Given this list of marker genes DPAGT1, PDCD7, SLC37A4, HTATSF1, CARHSP1, TMEM14A, NARS2, PPP1R7, PNKP, MAT2A, RNASE4, MARK3, EIF3L, SLC7A3, PANK2, PUS3, DUSP6, PRDX3, MOB1B, MRPL46, LAP3, WDR38, TNIP2, MAN2A1, PIK3R1, PPP4R3B, NDFIP2, GMDS, CRIP1, ACTR10, AHCYL1, CTDNEP1, MACIR, RAP1A, CXCR5, PI4K2B, ENO1, CPOX, NRBF2, CNOT6L, MTM1, SMARCA5, DUSP2, TM6SF1, BMAL1, RAMP1, RBM28, TMEM242, GOLPH3L, SSRP1, SLC35F5, TXN2, TAF12, MRPS35, DHX9, DDX46, CSNK2A1, MPHOSPH10, TNIK, EXOSC5 (exosome component 5), ALDH18A1, UBE3D, HLA-DOA, TDP1, PITPNA, MND1, ALG1, TMEM237, PARG, POLR3C, AIM2 (NCBI Gene Id 9447), ATP8B4, MDH1, MMS22L, OGDH, CNPY4, TMEM18, KMT2E, ALDOC, ZFYVE21, PPM1E, TMEM192, CD79A, MTHFD1, MRPS12 (mitochondrial ribosomal protein S12), AFG3L2, CWH43, SAT1, CDC5L, PAICS, BECN1, ATL2, TIA1, FAF2, SHMT1, DDX50, STAT1, GNB4, LINC00511 (long intergenic non-protein coding RNA 511), G6PD, CCDC51, FAM50A, CUL2, EIF2A, ZBTB12, RRAD, ARL4A, GNPNAT1, LYRM1, METTL27, CD69, TRAPPC3, USP31, ROM1, OTUD5, GBP7, SPIDR, MED11, PTGR2, WDR83, FBXO32 (NCBI Gene Id 114907), ZFAND5, SLC7A5, TMEM70, PIAS4, ANAPC16, TNFRSF18, GCSH, ECI1, POP4, ERAP1, EIF3D, ALG14, ERCC5 (NCBI Gene Id 2073), CASP8, TRMT6, HSD17B7, DDX5, DDX19B, RPS6KA3, ASTE1, B3GNT5, PIH1D2, MCOLN2, FAM133B, CSRP1, MTHFD1L, ZSWIM7, CSNK1A1, CYB5B, CRNKL1, NDUFAF7, EIF3J, BCAR3, BBS7, MAN1A1, PARP4, OSTM1, CPSF3, PON2, MTCP1, STK38, RPS21, UCHL1, KYAT3, NUDCD2, BORCS6, ZNF292, RBM22, ESD, TMEM11, TCEAL1, MTARC2, MTA2, PRXL2C, JOSD2 (Josephin domain containing 2), INIP, LDAF1, CEP135, NCK1, ABCB6, MTERF1, SATL1, CHAF1B, ATG5, NDST2, ZNF277, EFL1, NFS1, CRISP3, DHX15, GFM1, BRMS1 (NCBI Gene Id 25855), TIMM8B, P2RY10, FAM111A, PSAP, CBX8, CENPO, PAK1IP1, here is a description of the gene set: Human Gene Set: GSE20198_IL12_VS_IL12_IL18_TREATED_ACT_CD4_TCELL_UP studied in species Homo sapiens Genes up-regulated in the activated CD4 T cells (48h): IL-12 versus IL-12 and IL18. from publication Filén S, Ylikoski E, Tripathi S, West A, Björkman M, Nyström J, Ahlfors H, Coffey E, Rao KV, Rasool O, Lahesmaa R (PMID 20304822) The aim of this study was to identify genes regulated by IL-12, IL-18 and IFN-alpha during early differentiation of human Th1 cells